Given this list of marker genes SLC25A16, VNN2, AASDHPPT, PANK2, SLC25A42, VNN1, PANK4, here is a description of the gene set: Human Gene Set: GOBP_PANTOTHENATE_METABOLIC_PROCESS species: Homo sapiens The chemical reactions and pathways involving pantothenate, the anion of pantothenic acid, the amide of beta-alanine and pantoic acid. It is a B complex vitamin that is a constituent of coenzyme A and is distributed ubiquitously in foods.